The following is a description of a gene set: species: Homo sapiens Human Gene Set: HP_HYPOPLASIA_OF_THE_EAR_CARTILAGE Hypoplasia of the ear cartilage, and this is the list of marker genes: DDR2, LAGE3, WDR73, NUP107, YRDC, WDR4, TPRKB, GON7, TP53RK, OSGEP, NUP133, CD96